Given this list of marker genes NCF2, NOX3, NOX4, NCF4, PDGFB, NCF1, CYBB, AGT, SH3PXD2B, SH3PXD2A, NCF1B, NOXA1, NCF1C, NOXO1, NOX1, NOX5, here is a description of the gene set: Human Gene Set: GOMF_SUPEROXIDE_GENERATING_NADPH_OXIDASE_ACTIVITY studied in species Homo sapiens Catalysis of the reaction: NADPH + 2 O2 = H+ + NADP+ + 2 superoxide.